The following is a description of a gene set: Human Gene Set: GOBP_PROTEIN_HOMOTETRAMERIZATION The formation of a protein homotetramer, a macromolecular structure consisting of four noncovalently associated identical subunits. studied in species Homo sapiens, and this is the list of marker genes: GRIA3, TRPM2, USP16, SHMT2, HPRT1, CRYZ, HSD17B10, SAMHD1, HCN1, TRPA1, KCNN4, RYR3, EVL, TRPV5, B2M, DNM1, ALDH9A1, ME1, KCNT1, SYCP1 (synaptonemal complex protein 1), GOLGA2, SOD2, ACACB, ACOT13, CBY1, UPB1, GNMT, CTH, SSBP1, ALDH1A3, OSBPL2, THG1L, AQP10, TRPM7, GLS, RYR1, CRTC3, TRPV1, KIF25, AQP5, ALDH1A2, APIP, ALDOA, TK1, KCNJ12, CRTC2, PKD2, ACACA, TRPM4, TRPM3, PKD2L1, AQP4, GBP5, ITPR3, VASP, DEFA5, AQP2, CBR4, CRTC1, ITPR1, KCNJ2, MCOLN1, SHMT1, TDO2, APPL2, MAT1A